The following is a description of a gene set: This subpathway collects reactions regulating pyruvate metabolism. Reactome Pathway: Regulation of pyruvate metabolism part of: Pyruvate metabolism species: Homo sapiens, and this is the list of marker genes: LDHA, DLD, ME1, NEK1, PDK3, GID8, PKM, GSTZ1, RPS27A, RMND5B, PDK1, RMND5A, ARMC8, UBB (ubiquitin B), PDHX, PDK2, PDHA2, PDP1, UBA52 (ubiquitin A-52 residue ribosomal protein fusion product 1), PDK4, MKLN1, PDHA1, DLAT (dihydrolipoamide S-acetyltransferase, NCBI Gene Id 1737), RANBP9, MAEA, SIRT4, UBC, PDHB (pyruvate dehydrogenase E1 subunit beta), GID4, PGAM5, PDP2, PDPR, WDR26